The following is a description of a gene set: species: Mus musculus Combining with an icosanoid to initiate a change in cell activity. Mouse Gene Set: GOMF_ICOSANOID_RECEPTOR_ACTIVITY, and this is the list of marker genes: Ptgdr2, Ltb4r1, Ptgdr, Ptger1, Cysltr2, Ptger3, Ltb4r2, Slc22a22, Ppard, Ptger2, Cysltr1, Ptgfr, Hpgd, Tbxa2r, Ptger4, Ptgir (prostaglandin I receptor (IP))